The following is a description of a gene set: Human Gene Set: GSE22886_CD4_TCELL_VS_BCELL_NAIVE_UP species: Homo sapiens Genes up-regulated in comparison of naive CD4 T cells versus naive B cells. Immune cell-specific expression is one indication of the importance of a gene's role in the immune response. In order to identify such patterns, we set out to broadly profile gene expression in a variety of immune cells. from publication Abbas AR, Baldwin D, Ma Y, Ouyang W, Gurney A, Martin F, Fong S, van Lookeren Campagne M, Godowski P, Williams PM, Chan AC, Clark HF (PMID 15789058), and this is the list of marker genes: PRMT2, PLSCR3, GYPC, MNT, RTN3, POLR1E, CD7, GATA3, GZMM, GADD45A, PLEKHB1, UNC119B, MRPS15, ADGRE5, PIK3R1, MUTYH, ATP1A1, CDR2 (cerebellar degeneration related protein 2), CD28, SH2D1A, ELANE, FMNL1, CDC42 (NCBI Gene Id 998), NUCB2 (NCBI Gene Id 4925), TRAT1, AIF1 (allograft inflammatory factor 1), EVI2A, SF3A3 (NCBI Gene Id 10946), RGCC (NCBI Gene Id 730127), ENO2, CABIN1, GBA1LP, CD27, FKBP5, FXN, RUNX1, ADNP2, GARS1, CD5, TNFAIP3, ENO3, PSMD1, CDC25B, KAT8, SAMSN1, MAN2B2 (mannosidase alpha class 2B member 2), LTBP4, MAN2C1, PMM1, HIPK1, LINC00342, ARRB2, SAE1, INSL3, APBB1IP, SRGN, WNK1, PTPN4, IL7R, RPS6KB2, S100A4, DEXI, LEPROTL1, GUK1, PXN, GRSF1, ZBTB38, FCGRT, DDX28, RORA, ITPKB, TACC3, S100A10 (S100 calcium binding protein A10), ITGB1BP1 (integrin subunit beta 1 binding protein 1), TIAM1 (NCBI Gene Id 7074), AGBL5, UBASH3A, XAB2, SOCS3, SPOCK2, DNASE2, LTBP3, PBXIP1, CD6, GIMAP6, MPHOSPH10, BATF, TSPO, IQGAP2, CD2, CD3G, AIFM1, ITK, RALGDS (NCBI Gene Id 95849), BRF1, PKN1, NDFIP1, COMT, DVL1 (dishevelled segment polarity protein 1), ZYX, NOSIP (NCBI Gene Id 51070, nitric oxide synthase interacting protein), OPTN, SEMA4D, CD4, PITPNC1, SIGIRR, IL32, MOGS, NIPAL3, TXK (NCBI Gene Id 7294), MACROD1, AKTIP, KIF22, CAMK4, MAL, TXN2, SUPT5H, PRKCH, BIN2, DGKZ, BEX3, TBCD, CYTH2, TARP, SERINC3, NELL2, BLVRB, ZNHIT2, FYB1, ARL6IP4, CHD3, SERINC5, R3HDM1, CDKN2B, CD247, TFPT, PRDX3, GBP2, IL17RA, MAP3K6, NRBP1, APMAP, FLT3LG, MED15, PACS2, RGS10, TIMP1, GLT8D1, RSAD1, CCL5 (C-C motif chemokine ligand 5), ZAP70, IFITM3, EEIG1, ITM2A, BCL11B, PPP1R14B, KLHL21, SLC3A2, PRKCA, INPP4B, GNAQ, ZBTB22, ATP13A2, ZNF512B, LEF1, TRAC, DUSP7, GCHFR, DUSP2, APOL3, RSL1D1, SMAD7, BCR, CD3D, ID2, SMPD1, SOX4, PGGHG, IL27RA, SEPTIN6, LRFN3, LDLRAP1, ASB6, ECHDC2, PA2G4, UPP1 (uridine phosphorylase 1), M6PR, AZU1, ARID5A, PLPBP, EPHX2, MAP7D1, CITED2, GBP1, EXOSC7, ITGAL, SYNE1, BAG3, TOB1